Given this list of marker genes ATP5F1C, ATP5PB, MT-ATP8, ATP5MGL, ATP5F1E, ATP5F1B, ATP6V0C, ATP5F1EP2, ATP5MG, ATP5ME, ATP5F1D, ATP5F1A, ATP5MF, ATP5PF, MT-ATP6, ATP5PO, ATP5PD, here is a description of the gene set: species: Homo sapiens Enables the synthesis of ATP from ADP and phosphate by the transfer of protons from one side of a membrane to the other by a rotational mechanism driven by a gradient according to the reaction: ADP + H2O + phosphate + H+(in) -> ATP + H+(out). Human Gene Set: GOMF_PROTON_TRANSPORTING_ATP_SYNTHASE_ACTIVITY_ROTATIONAL_MECHANISM